The following is a description of a gene set: Clefting (gap or groove) of the upper lip affecting the lateral portions of the upper lip rather than the midline/median region. Non-midline cleft of the upper lip studied in species Homo sapiens Human Gene Set: HP_NON_MIDLINE_CLEFT_OF_THE_UPPER_LIP, and this is the list of marker genes: NECTIN1, PTCH1 (patched 1), SUMO1, PIGN, GFRA1, TP63, WNT3, HYLS1, FZD2, RSPO2, WNT9B, SPOP, TAPT1, TBX4, DDX59, KAT5, NBN, RET, GLI2, FGFR1, SMAD4, B3GLCT, HOXD13, SF3B4, ITGA8, GREB1L, RAB5IF, MED12, CHUK (component of inhibitor of nuclear factor kappa B kinase complex), GJA1, DHODH, KIF7, DLX4, TFAP2A, MSX1, IRF6, SMPD4, SIX3, CILK1, FGF20, MID1, GDF11 (NCBI Gene Id 10546)